Given this list of marker genes HHEX, EIF2AK4, PML, ZNF598, SH3BGRL, RPS6KB1, METAP2, EIF5, BOLL, EIF3H, AGO2, PAIP2, EIF4G2, FMR1, GIGYF2, MIF4GD, EIF4B, DAZ4, DAZL, EIF1, BANK1, NCBP1, HSPB1 (NCBI Gene Id 3315), YTHDF1, KHDRBS1, EIF4EBP1, NCBP2, EIF4G3, HABP4, CTIF, EIF4H, EIF3K, EIF3E, PPP1R15A, NCK2, EIF4G1 (NCBI Gene Id 1981), METTL3, EIF3B, RBM4, DAZ1, EIF4A2, PKP1, EIF4EBP2, EIF2B2, BZW1, PAIP1, UHMK1, EIF1B, TPR, RPL13A, C8orf88 (chromosome 8 open reading frame 88), YTHDF2, RPS6KB2, EIF2AK2, NCK1, ATF4, DNAJC3, PPP1CA, TNF (NCBI Gene Id 7124), SCRIB, DAZ2, DDX1, KLHL25, EIF2B5, AKT2, EIF2AK1, PAIP2B, DHX29, EIF4E2, YTHDF3, EIF5B, CCL5 (NCBI Gene Id 8147), NPM1, BZW2 (NCBI Gene Id 28969), ALKBH1, MTIF2, EIF2AK3, IMPACT, POLR2G, MTOR (NCBI Gene Id 2476), EIF4EBP3, LARP1, CSDE1, DAZ3, DDX3X, EIF2S1, here is a description of the gene set: species: Homo sapiens Any process that modulates the frequency, rate or extent of translational initiation. Human Gene Set: GOBP_REGULATION_OF_TRANSLATIONAL_INITIATION